The following is a description of a gene set: Human Gene Set: GOCC_SPERM_PRINCIPAL_PIECE studied in species Homo sapiens The segment of the sperm flagellum where the mitochondrial sheath ends, and the outer dense fibers (ODFs) associated with outer axonemal doublets 3 and 8 are replaced by the 2 longitudinal columns of the fibrous sheath (FS) which run the length of the principal piece and are stabilized by circumferential ribs. The principal piece makes up ~2/3 of the length of the sperm flagellum and is defined by the presence of the FS and of only 7 (rather than 9) ODFs which taper and then terminate near the distal end of the principal piece., and this is the list of marker genes: CABS1, NME8, AKAP3, ODF2, TMEM249, IFT81, IFT172, CATSPERE, SLC22A14, AKAP4, FSCB, CATSPERZ, PFKM, CATSPERB, CFAP119, CABYR, CCDC42 (NCBI Gene Id 146849), EFCAB2, CATSPER4, EFCAB9 (NCBI Gene Id 651812), SLC9B2, CATSPERG, FSIP2, SCNN1A, SPA17, IFT27, ATP2B4, SLC9B1, CATSPERD, CCR6, ENKUR, CATSPER1, C2CD6, PGAM4, TSGA10, SPAG6